The following is a description of a gene set: studied in species Homo sapiens Human Gene Set: MODULE_54 Cell cycle (expression cluster)., and this is the list of marker genes: NCAPH, PIMREG, AMPH, CNIH4, SRPK1, HJURP, CSE1L, HBB, GINS1, MANF, MID1, BIRC5, LBR, TIMELESS, NCAPD2, KIF23, ADA, EFHC2, CDC20, AURKB, DLEU1, LMNB1, LRP8, LMNB2, ITGA2, TOP2A, CMYA5 (cardiomyopathy associated 5), SCG5, RFC3, TUBA4A, FAM217B, CCNB1, TNFRSF12A, CCT5, CHAF1B, CCNB2, AIMP2, ATAD2, CHAF1A, ETV2, RHNO1, ZNF267, E2F8, CHEK1, ORC1, SQLE, TYMS, ANP32E, CDCA7, ELOVL6, CCL7, PAX4, AGXT, FAM83D, PTTG1, MB, HPRT1, SPAG5, WDR5, BPNT2, GGT1, BLM, KNSTRN, UBE2S, FEN1, DEPDC1, TOPBP1, RCC1, MT1H, OAS3 (2'-5'-oligoadenylate synthetase 3), DTYMK, CKS1B (NCBI Gene Id 88475), PMAIP1, GGH, SHCBP1, TPX2, ITGB3BP, BEST3, PBK, CENPA, PSPH, MSH2, SNRPA1, PLK4, HUWE1, PNP, NEIL3, TSN (NCBI Gene Id 7247), DDX11, PXMP4, WIZ, TACC3, CENPE, CDC25C, PKMYT1, RANBP1, PRDX1, TENM4, SMC4, ELOC, CDC6, MUCL1, TTK, ATF5, ZC3HC1, PFKP, RRM1, BUB1, RHOJ (ras homolog family member J), AMELY, AIF1L, KIFC1, FKBP1A, E2F1, GAD1, GPSM2, SGTB, CKAP2, RSPH14, PSRC1, PLAT, RRM2, PRDX4, ANLN, MCM4, JPT1, BEND3, TRIP13, PSMD14, ECT2, IFI30 (IFI30 lysosomal thiol reductase), H2AZ1, SLC7A7, ESM1, APOC2, LRRC17, UBE2T, DHFR, BYSL, UCHL5, TM4SF1, BARD1, TRIM24, MTFR2, HSPH1, ASPM, HMGCS1, CDKN2C, NDC80, PLP2, AGPAT5, TMEM106C, FXYD7, RAD54L, CDC25B, PRR11, MCM7, NME1, TUBA1A, ODC1, CTPS1, HMGB2, FSTL3, ACTG1, GMNN, PCLAF, CDCA5, BUB1B, MAPK13, BLTP2, IMPA2, NUDT1, CCNA2, APEX2, ZWILCH, RFC5, CTNNBIP1, PRIM1, H4C3, CENPF, SMC2, CKB, HMGA1, ZWINT, CDK4, KPNA2, ARL6IP1, CDKN3, CDC7, NT5DC2, KIF14, PIR, MAD2L1, RAD51, MCM5, MCM2, CDC45, HOXC10, HMMR, MKI67, FOXM1, POLQ, TROAP, NQO1, CCT6A, ASF1B, KIF2C, SNRPC, PCNA, CDKN1C, CCNE2, PHF5A (PHD finger protein 5A), GINS2, CEP55, CKS2, IARS1, RFC4 (replication factor C subunit 4), MAGED4B, SNRPE, UBE2C, AURKA, MYBL2, RPA3, NRM, UNG, CCNF, FOXD1, NUSAP1, KNTC1, TMEM40, APOBEC3B, MCM3, POLE2, PLIN2, MCM6, PLK1, SLC16A3, NEK2, NUF2 (NCBI Gene Id 83540), H2AX, ADSL, AHCY (NCBI Gene Id 191), POLD1, DLGAP5, SNRPB, DEPDC1B (DEP domain containing 1B), ARHGAP11A, CDH1, NRIP3, MELK, NEMP1, CDK1, KIF11, SNRPF, LAPTM4B, SLC7A5, SLC25A5, TPI1, MTHFD2, RECQL4, PUM3, GPN2